The following is a description of a gene set: species: Homo sapiens The chemical reactions and pathways involving prostanoids, any compound based on or derived from the prostanoate structure. Human Gene Set: GOBP_PROSTANOID_METABOLIC_PROCESS, and this is the list of marker genes: GSTA1, PLA2G4A, MIR204, AKR1C4, PTGS1, CD74, ACOX1 (acyl-CoA oxidase 1), CTHRC1, MIF, CYP4F8, PTGES2, PLAA, GSTP1, PTGDS, PRXL2B (NCBI Gene Id 127281), PLA2G4F, GSTM1, MIR132, AKR1B1 (aldo-keto reductase family 1 member B), DAGLB, PTGS2, AVPR1A, PTGES3, AKR1C3, PTGIS, ATP6V1B1, AKR1C1, IL1B, PLA2G3, TBXAS1, FABP5, EDN1, AKR1C2, TNFRSF1A, MGST3, AVP, EDN2, PTGES, PTGR1, COMT, HPGD, PNPLA8, PTGR2, PIBF1, CYP2S1, SIRT1 (sirtuin 1), CBR1, PLA2G10, CES2, HPGDS, MIR766